The following is a description of a gene set: electronically inferred by orthology from the curated human pathway Reactome Pathway: Ephrin signaling This event has been computationally inferred from an event that has been demonstrated in another species.<p>The inference is based on the homology mapping from PANTHER. Briefly, reactions for which all involved PhysicalEntities (in input, output and catalyst) have a mapped orthologue/paralogue (for complexes at least 75% of components must have a mapping) are inferred to the other species. species: Mus musculus part of: EPH-Ephrin signaling, and this is the list of marker genes: Sdcbp, Ephb1, Pak3, Efnb2, Ephb3, Efnb3, Ephb4, Fyn, Ephb6, Ephb2 (Eph receptor B2), Arhgef7, Efnb1